Given this list of marker genes Coro1a, Cd300a, Klf2, Dipk1a, Samhd1, Fosb, Plac8, Rnase6, Adgre4, Ccr2, Gngt2, Ctdsp2, Nadk, Lst1, Serinc3, Lyl1, Abi3 (NCBI Gene Id 66610), Nfix, Cx3cr1, Cd47, Hpgd, Cdc42ep3, Rsad2, Padi2, Rassf4, H2az1, Fam111a, Hspa1b, Svip, Anxa1, Hpse, Arhgef18, Ier5, Camk1d, Pi16, Ptprc (NCBI Gene Id 19264), Rel, Cox7a2l, Lpl, Dpy19l1, Atf3, Pou2f2, Rras, Hacd4, Unc93b1, Ptpro, Crip1, Rgs2, Tmcc1, Psap, Clec12a, Rgs10, Ifngr1, Arhgap9, Ppfia4, Nrp1, Npc2, Aim2, Btg2, Gpx1, Ly86, Lmo1, Itgb7, Naca, Map4k2, Hspa1a, Zcchc24, Nr4a1, Arhgap45, Lyz2, Abca9 (NCBI Gene Id 217262), Rasgrp2, Sema4d, Cd52, Ifit3, Arl5c, Cd180, Nxpe4, Evi2a, Add3, Fry, Lsp1, Jund, Ypel3, Pdlim1, Alox5ap, H2-D1, Higd2a, Ldlrad3, Mef2c, Fau, Limd2, Itm2b, Calhm6, Pld4, Tnfrsf1b, Klf4, Eif3f, Samsn1, Ptpn18, Mbp, Tnfaip8l2, Meaf6, Smpdl3a, Ctsh, Cyp27a1, Ctps2, Camkk2, Ankrd44, Sat1 (spermidine/spermine N1-acetyl transferase 1), Smim5, Eef2 (NCBI Gene Id 13629), Ramp1, Metrnl, Lyst, Tppp3, Samd9l, Glipr1, Vwa5a, Sp140, Selenop, Arhgap15, Plbd1, Niban1, Tmem176b (transmembrane protein 176B), Cybb, Dnase1l1, Sowahc, Dgkg, here is a description of the gene set: Mouse Gene Set: CUI_MONOCYTE_IL1B_RESPONSE_DN species: Mus musculus Cytokines mediate cell-cell communication in the immune system and represent important therapeutic targets. A myriad of studies have highlighted their central role in immune function, yet we lack a global view of the cellular responses of each immune cell type to each cytokine. To address this gap, the authors created the Immune Dictionary, a compendium of single-cell transcriptomic profiles of more than 17 immune cell types in response to each of 86 cytokines (>1,400 cytokine-cell type combinations) in mouse lymph nodes in vivo. A cytokine-centric view of the dictionary revealed that most cytokines induce highly cell-type-specific responses. For example, the inflammatory cytokine interleukin-1β induces distinct gene programmes in almost every cell type. A cell-type-centric view of the dictionary identified more than 66 cytokine-driven cellular polarization states across immune cell types, including previously uncharacterized states such as an interleukin-18-induced polyfunctional natural killer cell state. from publication Cui A, Huang T, Li S, Ma A, Pérez JL, Sander C, Keskin DB, Wu CJ, Fraenkel E, Hacohen N (PMID 38057668) Genes negatively differentially expressed in cell type: Monocyte upon treatment with cytokine: IL-1β in mouse lymph nodes in vivo.